Given this list of marker genes Slc6a8, Slc6a1, Slc6a13, Slc6a6, Slc6a11, Slc6a12, here is a description of the gene set: Enables the transfer of a solute or solutes from one side of a membrane to the other according to the reaction: gamma-aminobutyric acid(out) + Na+(out) + Cl-(out) = gamma-aminobutyric acid(in) + Na+(in) + Cl(in). Mouse Gene Set: GOMF_GAMMA_AMINOBUTYRIC_ACID_SODIUM_CHLORIDE_SYMPORTER_ACTIVITY studied in species Mus musculus